Given this list of marker genes Pigo, Dpm3, Gpaa1 (NCBI Gene Id 97971), Fut4, Cwh43, Pigl, St6galnac5 (ST6 (alpha-N-acetyl-neuraminyl-2,3-beta-galactosyl-1,3)-N-acetylgalactosaminide alpha-2,6-sialyltransferase 5), Mfsd8, Tm9sf2, Slc30a5, B3galt4, Gal3st1, St8sia5, Mppe1, A4galt, Kit, B4galt6, Gal3st3, Neu3, Glb1, Hexb, Pgap3, St3gal3, Naga, Prkcd, Pnliprp2, St8sia4, St8sia2, St3gal1, Pign, St6galnac1, B4galnt1, Naglu, Gal3st2, St3gal2, Gla, Fut2, St6galnac3, Pigt, Pigp, Gba2, Lct, Pigz, Neu4, Pigk (NCBI Gene Id 66613), B3galt2, Pigv (phosphatidylinositol glycan anchor biosynthesis, class V), Pigx, Aoah, Itgb8, Pigf, Neu1, Abca2, Sccpdh, St8sia3 (NCBI Gene Id 20451), Pgap2, Dpm2, B4galt4 (UDP-Gal:betaGlcNAc beta 1,4-galactosyltransferase, polypeptide 4), Neu2, St6galnac4, Fut9, 6430550D23Rik, Pigh, Galc, B4galt3, Map7, A3galt2, Gba1 (glucosylceramidase beta 1), Pigq, Fa2h, Pigyl, B3galt1, B4galt5, St3gal6, Pigm, Pigw, Piga, Pyurf, St8sia6, St3gal4, Cln6, Pigu, Pigs, Pigb, Dpm1, Pigc, Gbgt1, Ugcg, Ugt8a, Bax, Crem, Psap, Gm2a, Pgap1, Pigg, St6galnac6, Hexa, Pgap4, here is a description of the gene set: species: Mus musculus The chemical reactions and pathways involving liposaccharide. Mouse Gene Set: GOBP_LIPOSACCHARIDE_METABOLIC_PROCESS